The following is a description of a gene set: Hedgehog signaling pathway studied in species Mus musculus Mouse Gene Set: WP_HEDGEHOG_SIGNALING_PATHWAY, and this is the list of marker genes: Ptch1, Hhip, Sufu, Sin3a, Ski, Crebbp (CREB binding protein), Stk36, Smo, Shh, Ptch2, Dyrk1a, Gli2, Rab23 (NCBI Gene Id 98704), Sap18 (NCBI Gene Id 52619), Igf2, Dhh, Ccnb1, Ihh, Gli3, Cdk1, Gas1, Gli1